The following is a description of a gene set: species: Homo sapiens The chemical reactions and pathways involving leukotriene, a pharmacologically active substance derived from a polyunsaturated fatty acid, such as arachidonic acid. Human Gene Set: GOBP_LEUKOTRIENE_METABOLIC_PROCESS, and this is the list of marker genes: ALOX5, MGST3, CYP4A11, PLA2G5, GGT3P, MAPKAPK2, MGST2, PRG3, NCF1, GGT6, LTA4H, GGTLC1, CYP4F2, SYK, LTC4S, GGTA1, ABCC10, CYP4F3, ABCC1, ALOX5AP, CPA1, PLA2G4A, GGT5, PLA2G1B, DPEP2, GGT1, GGT2P, GGT7, GGTLC2, PTGR1, GGTLC3, DPEP1, CYP4F12, ALOX12